Given this list of marker genes Csde1, Xpo5, Snd1, Ago2, Dhx9, here is a description of the gene set: Mouse Gene Set: GOMF_RISC_COMPLEX_BINDING Binding to a RISC complex. studied in species Mus musculus